Given this list of marker genes Ufm1, Os9, Insig1, Ywhab, Txn1, Fermt1, Rangap1, Cd36, Sumo1, Angpt1, Sirt6, Ei24, Adipoq, Hdac3, Derl3, Pkia, Cdk5, Rab23, Park7, Mdfic, Yod1 (YOD1 deubiquitinase), Svip, Ubac2, Cabp1, Akap1, Bard1 (BRCA1 associated RING domain 1), Hnf4a, Pkig, Nfkbia, Erlec1, Ube2j1, Apod, Nf1, Gbp4, Ube2g2, Sp100, Derl2, Fam76b, Chp1, here is a description of the gene set: Any process that decreases the frequency, rate or extent of the directed movement of proteins within cells. Mouse Gene Set: GOBP_NEGATIVE_REGULATION_OF_INTRACELLULAR_PROTEIN_TRANSPORT studied in species Mus musculus